Given this list of marker genes PRKAG2-AS2, TCEAL1, JUNB, CEMP1, GPR82, NOTCH3, RASSF9, THBS1, S100A8, GPCPD1, HAMP, MAFG, DDI1, SLC43A3, MTHFD2L, ZSCAN23, CDKN3, C22orf42, ENTPD7, FBLIM1, ADAD2, ATP6V1B2, PLA2G4A, INHBA, CYB561A3 (cytochrome b561 family member A3), PPIF, PIM3, RNF24, USF2, LINC00324, NIBAN2, CDKN1A, DACT3, PTH2R, BATF, TEK, KRT4, CXorf58, P2RX4, PKM, RBMS2, CCR2, SPATA24, CSF2RA, HCAR3, P2RX7, CCL8, SLC39A8, SNX9, DSTYK, CTSB, CEP55, TSPAN33, SLAMF7, NUDT12, SUPT6H, CCR5, PRDX1, CASP1, THUMPD3-AS1, ACACB, IRS2, GPR182, ORAI1, CLN3, HSPB7, NFKB1 (nuclear factor kappa B subunit 1), PRELID2, SLCO4A1, GADD45B, HLA-DRB1, ADIPOR1 (adiponectin receptor 1), ICAM1, INSIG1, TNF, E2F7, MAD2L2, LINC00926, CLDN11, NIPA1, LILRB1, FLT4, DPCD, CDC42EP1, RASSF2, ADCY6, LINC00856, EFS, NCAPH, MDH1B, LHFPL2, FAM182B, LIF, SPRED2, ULBP2, SHISA6, EGF, CPNE8, NDP, ADM, NBEAL2, AREG, CNTROB, LRRC34, UBE2S, BASP1, MIR30C2, SELENOO, GDI1, SOCS1 (NCBI Gene Id 8651), MYL11, ADGRE1, SPAG5-AS1, LENG1, GABBR1, TSC22D3, FOXN3, PLAT, PRPH, RHBDL1, VENTX, ITGB2, ATP7B, MED14, DENND4A, SCML4, ENPP2, NTAQ1, EPOP, LILRA2, CLDN14, RUNX3, PNKD, FCGR2C, C8orf88, MAGEB2, GLRX (NCBI Gene Id 90885), CELF4, OLIG1, IFI16, PBOV1, AGRN, ZNF541, SGCG, KLLN, SPATA31C2, BHLHE40, CYBB, TBC1D2B, TRPM2, GCLC, LITAF, GRHL3, FUT8, IKBKE, HAS1, CTDSP1, LILRA1, SEL1L2, NDRG4, DEFB125, FANCC, PITX3, GCNT2, TRIM2, MIR21, ESAM, EPHX4, KCNC4, PXN, MYO1E, BTG2, SMAP2, AHRR, LINC01015, GGA1, CBY1, DNAJB4, GOT1, ATP6AP1-DT, C15orf39, FOXD4, BRAF, CECR2, NEDD4L, CD274, LINC00955, KLF8, STEAP4, TRPT1, here is a description of the gene set: Human Gene Set: GSE2128_CTRL_VS_MIMETOPE_NEGATIVE_SELECTION_DP_THYMOCYTE_C57BL6_UP Fetal thymic organ culture (FTOC) DC2.5 CD4+CD8+ thymocytes from B6g7 or NOD background. 0 or 16 hour after addition of the BDC mimitope from publication Zucchelli S, Holler P, Yamagata T, Roy M, Benoist C, Mathis D (PMID 15780994) Genes up-regulated in C57BL6 CD4 CD8 double positive thymocyte transgenic for the BDC2.5 TCR incubated with no peptide 0h versus C57BL6 CD4 CD8 double positive thymocyte transgenic for the BDC2.5 TCR incubated with mimetope negative sel 16h. species: Homo sapiens